The following is a description of a gene set: Petechiae are pinpoint-sized reddish/purple spots, resembling a rash, that appear just under the skin or a mucous membrane when capillaries have ruptured and some superficial bleeding into the skin has happened. This term refers to an abnormally increased susceptibility to developing petechiae. Human Gene Set: HP_PETECHIAE Petechiae species: Homo sapiens, and this is the list of marker genes: PRKAR1A, FIP1L1, LYZ, GP1BB, PLCG1, NABP1 (NCBI Gene Id 64859), JAK2, NEU1, TREX1, ITGA2B, HOXA11, STXBP2 (NCBI Gene Id 6813), FYB1, STAT3, CLCN7, F8, TET2, OCLN, NUMA1, USP18, APOE, LCP2, GFI1B, DPP9, RAB27A, NPM1, UNC13D, RARA, TBL1XR1, SAMD9, GBA1, BCOR, ITGA2, FERMT3, PRF1, HCK, CD109, GIMAP5, GATA1, F9, FCGR2C, GP9, FUCA1, IRF2BP2, GNA14, ITGB3, ETHE1, STAT5B, DCLRE1B, WAS, PTPRJ, MPL (MPL proto-oncogene, thrombopoietin receptor), ZBTB16, GP1BA, NAGA, GNE, PEPD, WIPF1, STX11, PML, RUNX1, CASP10, ETV6, CALR